The following is a description of a gene set: studied in species Homo sapiens Human Gene Set: DESCARTES_FETAL_PANCREAS_STROMAL_CELLS from publication Cao J, O'Day DR, Pliner HA, Kingsley PD, Deng M, Daza RM, Zager MA, Aldinger KA, Blecher-Gonen R, Zhang F, Spielmann M, Palis J, Doherty D, Steemers FJ, Glass IA, Trapnell C, Shendure J (PMID 33184181) The gene expression program underlying the specification of human cell types is of fundamental interest. The study authors generated human cell atlases of gene expression and chromatin accessibility in fetal tissues. For gene expression, the study authors applied three-level combinatorial indexing to >110 samples representing 15 organs, ultimately profiling ~4 million single cells. The study authors leveraged the literature and other atlases to identify and annotate hundreds of cell types and subtypes, both within and across tissues. Our analyses focused on organ-specific specializations of broadly distributed cell types (such as blood, endothelial, and epithelial), sites of fetal erythropoiesis (which notably included the adrenal gland), and integration with mouse developmental atlases (such as conserved specification of blood cells). These data represent a rich resource for the exploration of in vivo human gene expression in diverse tissues and cell types. Marker genes curated from the annotated cluster as represented in the Descartes Human Gene Expression During Development database., and this is the list of marker genes: MIR218-1, BHLHE22-AS1, LVRN, MMP23B, ANGPTL1, ENSG00000231424, RTL3, RSU1P3, PITX1, CCL11, FMO1, MFAP5, SFRP2, ABCA10, NFE4, NRK, LPAR4, SLC7A10, TSGA13, THBS2, MIR1245A, ANGPTL6, ABCA6, NTF4, AGTR2, SHOX2, LINC01819, ABCA9